Given this list of marker genes PCP4, HLA-DQB1 (major histocompatibility complex, class II, DQ beta 1), IGHG1, CD74, IGLC2, ZYX, IGKC, IGHA1, IGLV2-14, HLA-DPA1, WARS1, TRBC2, HLA-DRB1, FGFR1, HLA-DPB1, HLA-DRA, NUPR1, PLTP, IGHV3-69-1, IGHV3-23, here is a description of the gene set: species: Homo sapiens from publication Lui WO, Foukakis T, Lidén J, Thoppe SR, Dwight T, Höög A, Zedenius J, Wallin G, Reimers M, Larsson C (PMID 15608688) Human Gene Set: LUI_THYROID_CANCER_CLUSTER_4 Cluster 4: genes with similar expression profiles across follicular thyroid carcinoma (FTC) samples. The demonstration of the PAX8-PPAR(gamma) fusion oncogene in a subset of follicular thyroid tumors provides a new and promising starting point to dissect the molecular genetic events involved in the development of this tumor form. In the present study, we compared the gene expression profiles of follicular thyroid carcinomas (FTCs) bearing a PAX8-PPAR(gamma) fusion against FTCs that lack this fusion. Using unsupervised clustering and multidimensional scaling analyses, we show that FTCs possessing a PAX8-PPAR(gamma) fusion have a highly uniform and distinct gene expression signature that clearly distinguishes them from FTCs without the fusion. The PAX8-PPAR(gamma)(+) FTCs grouped in a defined cluster, where highly ranked genes were mostly associated with signal transduction, cell growth and translation control. Notably, a large number of ribosomal protein and translation-associated genes were concurrently underexpressed in the FTCs with the fusion. Taken together, our findings further support that follicular carcinomas with a PAX8-PPAR(gamma) rearrangement constitute a distinct biological entity. The current data represent one step to elucidate the molecular pathways in the development of FTCs with the specific PAX8-PPAR(gamma) fusion.